Given this list of marker genes Drd2, Tnf, Nron, Tmem225, Epm2a, Inpp5k, Uri1, Tmem132c, Chp1, Bag4, Iqgap1, Hpn, here is a description of the gene set: species: Mus musculus Mouse Gene Set: GOBP_NEGATIVE_REGULATION_OF_DEPHOSPHORYLATION Any process the stops, prevents, or reduces the frequency, rate or extent of removal of phosphate groups from a molecule.